Given this list of marker genes PHACTR1, FOSB, PLAUR, KLF4, IFITM1, SGK1, TUBA1B (NCBI Gene Id 88851), TUBA1A, NR4A1 (nuclear receptor subfamily 4 group A member 1), BTG2, HLA-DQA1, HLA-DRA, IFITM3, G0S2, HBEGF, HLA-DRB1, RGS2, ZFP36, TMEM176B, FCGR3A, here is a description of the gene set: Genes downregulated in Monocytes from Idiopathic Pulmonary Fibrosis Patients vs. Controls Thirty-eight PBMC samples from 25 patients with IPF and 13 matched controls yielded 149,564 cells that segregated into 23 subpopulations. Classical monocytes were increased in progressive and stable IPF compared to controls (32.1%, 25.2%, 17.9%, respectively, p<0.05). Total lymphocytes were decreased in IPF vs controls, and in progressive vs stable IPF (52.6% vs 62.6%, p=0.035). Tregs were increased in progressive vs stable IPF (1.8% vs 1.1% of all PBMC, p=0.007), although not different than controls, and may be associated with decreased survival (P=0.009 in Kaplan-Meier analysis; P=0.069 after adjusting for age, sex, and baseline FVC). Flow cytometry analysis confirmed this finding in an independent cohort of IPF patients. Fraction of Tregs out of all T cells was also increased in two cohorts of lung scRNA-seq. CCL22 and CCL18, ligands for CCR4 and CCR8 Treg chemotaxis receptors, were increased in IPF. The single-cell atlas of the peripheral immune system in IPF, reveals an outcome-predictive increase in classical monocytes and Tregs, as well as evidence for a lung-blood immune recruitment axis involving CCL7 (for classical monocytes) and CCL18/CCL22 (for Tregs). (From Abstract) from publication Unterman A, Zhao AY, Neumark N, Schupp JC, Ahangari F, Cosme C Jr, Sharma P, Flint J, Stein Y, Ryu C, Ishikawa G, Sumida TS, Gomez JL, Herazo-Maya JD, Dela Cruz CS, Herzog EL, Kaminski N (PMID 38717443) studied in species Homo sapiens Human Gene Set: UNTERMAN_IPF_VS_CTRL_MONOCYTE_DN